The following is a description of a gene set: Mouse Gene Set: GOBP_PROTEIN_LOCALIZATION_TO_PLASMA_MEMBRANE_RAFT studied in species Mus musculus A process in which a protein is transported to, or maintained in, a location within a plasma membrane raft., and this is the list of marker genes: Myadm, Clip1, Tsc2, Negr1 (NCBI Gene Id 320840), Flot2, L1cam, Umod